Given this list of marker genes MARCKSL1, TNFRSF21, TP53INP2, NEUROG1, HOXA7, SPATC1, P2RX3, UBQLNL, PSD3, TMEM270, OGDH, ZNF516-DT, RAI1, LGI3, MOSMO, USP3, MAPK3, PAPOLG, TAFA1, RESF1, AQP7, UBE2H (NCBI Gene Id 7328), PDPK1, CCR9, UQCC2, SPATA20, STAT6, FAM76B, ITPRIPL1, FGF13, PRM3 (NCBI Gene Id 59068), ZHX2, TMTC2, DUSP4, ECI1, KCNK7, DMP1, SCAI, COA8, C16orf78, SMAD6, ZC3H10, TLE3, DNAJC5B (DnaJ heat shock protein family (Hsp40) member C5 beta), RPL41, ST8SIA4, BAG5, AZIN1, AGRP, OR2K2, GSC, NEUROD6, PCBP1, CPS1, SPTAN1, TSC22D1, KBTBD12, MYBPH, SLC4A2, DUSP3, NDST4, NR6A1, RIN1, TBL1Y, SPATC1L, CREM, EPAS1, UBQLN3, PDZRN4, SEH1L, HIF3A, PDP1, SPATA3, TBL1X, NRXN1, NEUROD2, AKIRIN1, SAMD8, CEP57, RIMS2, FAM241B, DUSP13B, ASB17, G3BP2, BNIP3L, SYT4, ISCA1, VCAN, TAFAZZIN, C3AR1, SAXO1, RNF44, ACTL7B, ELOVL5, PDS5A, GDPD2, GSTO2, CDK5, EGR3, here is a description of the gene set: species: Homo sapiens Genes having at least one occurrence of the highly conserved motif M149 YGACNNYACAR in the regions spanning 4 kb centered on their transcription starting sites. The motif does not match any known transcription factor binding site. Human Gene Set: YGACNNYACAR_UNKNOWN Comprehensive identification of all functional elements encoded in the human genome is a fundamental need in biomedical research. Here, we present a comparative analysis of the human, mouse, rat and dog genomes to create a systematic catalogue of common regulatory motifs in promoters and 3' untranslated regions (3' UTRs). The promoter analysis yields 174 candidate motifs, including most previously known transcription-factor binding sites and 105 new motifs. The 3'-UTR analysis yields 106 motifs likely to be involved in post-transcriptional regulation. Nearly one-half are associated with microRNAs (miRNAs), leading to the discovery of many new miRNA genes and their likely target genes. Our results suggest that previous estimates of the number of human miRNA genes were low, and that miRNAs regulate at least 20% of human genes. The overall results provide a systematic view of gene regulation in the human, which will be refined as additional mammalian genomes become available. from publication Xie X, Lu J, Kulbokas EJ, Golub TR, Mootha V, Lindblad-Toh K, Lander ES, Kellis M (PMID 15735639)